The following is a description of a gene set: part of: mitochondrial fatty acid beta-oxidation of saturated fatty acids Reactome Pathway: Beta oxidation of myristoyl-CoA to lauroyl-CoA species: Homo sapiens The second pass through the beta-oxidation spiral starts with the saturated fatty acid myristoyl-CoA (from the first swing through the beta oxidation spiral) and produces lauroyl-CoA. Four enzymatic steps are required starting with LCAD CoA dehydrogenase (Long Chain) activity, followed by three enzymatic steps, enoyl-CoA hydratase, 3-hydroxyacyl-CoA dehydrogenase, and ketoacyl-CoA thiolase activities, all present in the mitochondrial membrane associated trifunctional protein., and this is the list of marker genes: ACADL, HADHB, HADHA